The following is a description of a gene set: species: Mus musculus Catalysis of the reaction: UDP-N-acetyl-D-galactosamine + polypeptide = UDP + N-acetyl-D-galactosaminyl-polypeptide. This reaction is the modification of serine or threonine residues in polypeptide chains by the transfer of a N-acetylgalactose from UDP-N-acetylgalactose to the hydroxyl group of the amino acid; it is the first step in O-glycan biosynthesis. Mouse Gene Set: GOMF_POLYPEPTIDE_N_ACETYLGALACTOSAMINYLTRANSFERASE_ACTIVITY, and this is the list of marker genes: Galnt7, Galnt6, Galnt1, Galnt9, Galnt18, Galnt4, Galnt15, Galntl6, Galnt11, Galnt5, Galnt17, Galnt3, Galnt14, Galnt13, Galnt16, Galnt2, Galnt10, Galnt12